Given this list of marker genes PLXNB2, ASPHD1, CLN8, PHACTR2, KCNQ1DN, FSCN1, DAPK1, ARSB, MRAS, CLEC10A, PILRA, CD209, MICAL2, ARRB1, MYOF, ABHD2, FBXW10B, MEP1A, RAB11A, TNS1, AURKA, RCAN1, HSD11B1, VPS41, MITF, ZBTB43, PGBD5, CLEC5A, ENC1, DHRS9, TMEM53 (NCBI Gene Id 79639), NPC1, SETD3, CHI3L1, ACO1, PPP2R3A, FZD5, CDKN1A, IFNA14, SPSB1, EML4, ATP6V1H, ALOX15, COL8A2, AHNAK2, RHEB, CXCR2, SLC31A2, SLC19A1, TUBB6, CLPB, PSEN2, RAB8B, GALNT12, SNX5, KCNJ1, ATF3, ACAT2, GBX2, H2BC4, LAMP1, PZP, DSC2, STX3, MACROH2A2, CTNS, RXRA, PLXND1, ROBO3, SMIM7, LSM1, PODXL, MYF6, ALDH1A1, ABCC3, CRTAM, BST1, CCRL2, PTGS1, SPRY2, POLD3, CEBPB, PPIP5K1, NME8, BEX1, PAPSS1, FHOD1, TNFRSF21, PEPD, FUCA1, TST, ARMCX1, PDGFA, MPP1, MAOB, TK2, IPCEF1, TPP1, SCEL, CACNA2D3, TNFRSF1A, ALAS1, ULK2, HK3, PLAU, ALDH2, H3C12, PTTG1IP, ACOT7, SYNGR1, SOCS2, MS4A4A, UBAP1, CSRP2, FAM114A1, KATNB1, CENPN, ARHGAP10, TBXAS1, PAX3, RAMP1, LRRFIP1, VCL, AGPS, SLC31A1, CDS2, SLC27A3, CCN3, FKBP5, FOSL1 (NCBI Gene Id 8061), EGLN3, MYO10, PALLD, PEA15, RAI2 (retinoic acid induced 2), PEX19, ARHGEF10L, NRP1, GSTT2, SAMHD1, ERO1A, SEC23B, RAB31, SFT2D2, TACSTD2, GPD1, CLTC, RAP2A, FN1, CYP27B1, AIF1, ACOX2, CXCL8, EVC, MAOA, P4HA2, CD1E, SLC2A9, FAM162A, LILRA2 (leukocyte immunoglobulin like receptor A2), NLRP3, CTSO, MMP19, SUOX, SDC4, NFIL3, PDGFC, RGCC, CD1C, MCUR1, TM6SF1, TYROBP, APP, FOXE3, TMCC1, WIPI1, DYNC1I2, TGFBR3, TAL1, PDE4A, ADCK2, ADORA2B, E2F6, CTH, FBP1, PFKP, CD83, GALNT11, CD36, CCR5, ABHD6, CTNNAL1, MIEF1, CD86, WNT5B, DHCR24, SORT1, USP32, PPP1R3D, ANXA1, here is a description of the gene set: studied in species Homo sapiens Human Gene Set: GSE3982_DC_VS_BCELL_UP from publication Jeffrey KL, Brummer T, Rolph MS, Liu SM, Callejas NA, Grumont RJ, Gillieron C, Mackay F, Grey S, Camps M, Rommel C, Gerondakis SD, Mackay CR (PMID 16474395) Genes up-regulated in comparison of dendritic cells (DC) versus B cells. In the present study we used Affymetrix oligonucleotide microarrays to produce gene transcription profiles for the major leukocyte types in humans. This comprehensive dataset enabled us to not only establish which genes were expressed in each leukocyte type, but also which genes were expressed in each subset after activation. The used of a comprehensive dataset of gene profiles from all the major human leukocyte subsets enabled a novel and powerful means for identification of genes associated with single leukocyte subsets, or different immune paradigms.